Given this list of marker genes Or13c7, Col15a1, Trmo, Gm12458, Gm16731, Gm829, Msantd3, Nr4a3, Or13c7e-ps1, Xpa, Gm12435, Stra6l, Reck, Mrpl50, Tdrd7, Slc25a51, Trim14, Ncbp1, Gm22685, Gm12412, Ccin, Aldob, Gm12430, Gm22670, Erp44, Or13c7d, Mir5120, Gm12585, Gm23746, Or13j1, Igfbpl1, Coro2a, Aldh1b1, Rnf20, Mir1958, Tbc1d2, Anp32b (NCBI Gene Id 67628), Gm26424, Tmod1, Tgfbr1, Rbpj-ps1, Or13c7c, Gm12408, Gm12679, Shb (NCBI Gene Id 230126), Anks6, Gm12436, Gm12426, Invs, Pgap4, Gm12451, Baat, Gm12462, Mir5106, Amd-ps4, Cavin4, Tstd2, Alg2, Tex10, Gm12422, Gm12447, Grhpr, Clta, Gm12446, Galnt12, Hrct1 (histidine rich carboxyl terminus 1), Gm12411, Gm25485, Dcaf10 (NCBI Gene Id 242418), Grin3a, Stx17, Zcchc7, Gm12460, Acnat1, Fbxo10, Acnat2, Gm12452, Gm12459, Ccdc180, Gm12445, Tomm5, Gm12439, Sec61b, 5730488B01Rik, Melk, Zfp189, Gabbr2, Hemgn, Cylc2, 4930517J16Rik (RIKEN cDNA 4930517J16 gene), Foxe1, Polr1e, Frmpd1os, Gm22042, Or13d31-ps1, Or13c7b, Nans, Gm22247, Gm23043, Frmpd1, Gm12453, Gm12463, Ppp3r2, Tmeff1, Rnf38, Exosc3, Gm568, 1700055D18Rik, Trmt10b, Pax5, Zbtb5, Gm12492 (predicted gene 12492), Plppr1, Glipr2, Gm22055, Or13e8 (NCBI Gene Id 56014), Gm12678 (predicted gene 12678), Gm12444, Gm24376, Gm12409, Gm12443, Gne, Gm12503, Spaar, here is a description of the gene set: species: Mus musculus Mouse Gene Set: chr4B1